Given this list of marker genes IL6ST, SOCS3, IL6R, CBL, PTPN11, TYK2, STAT1, IL6, JAK2, STAT3, JAK1, here is a description of the gene set: studied in species Homo sapiens Interleukin-6 signaling Human Gene Set: REACTOME_INTERLEUKIN_6_SIGNALING